The following is a description of a gene set: species: Homo sapiens Human Gene Set: HP_ABNORMAL_ANKLE_MORPHOLOGY Abnormal ankle morphology A structural anomaly of the ankle., and this is the list of marker genes: NSD1, COG8, FIG4, SLC4A10, ADSS1, ADAMTS15, COL25A1, EXT2, SVIL, ANGPT2, ATP5F1D, GABRG2, ERGIC1, ORAI1, FLNA, ITGA7, DPM1, CYP2R1, COL6A1, COL6A2, FGF13, MMP2, PNPT1, SCN1B, SYT2, COL6A3, EXT1, TNNT1, PIEZO1, NEB, SCN9A, SCN2A, UBA1, MAP3K20, MYL2, ACTA1, FKBP10, SELENON, IL2RA, HACD1, MAFB, IDH1, PTPN2, PSAT1, CHMP1A, SPG11, RYR1 (NCBI Gene Id 906), ANO5, ERLIN2, RAB3GAP2, ALAD, NFATC2, DYRK1A (dual specificity tyrosine phosphorylation regulated kinase 1A), SLC1A4, CD247, SCYL2, APC2, VARS1, PTPN22, VDR, NT5C2, COL10A1, LIFR, C18orf32, DAG1, SCN1A, KLHL9, HNRNPA2B1, MAN2B1, PRRT2 (proline rich transmembrane protein 2), C19orf12, DDR2, TPM3, ANKRD55, RTTN, SPTBN4 (NCBI Gene Id 80322), HNRNPH1 (heterogeneous nuclear ribonucleoprotein H1), STX1B, ESCO2, ADGRV1, IL2RB, GJC2, RPL10, SLC34A3 (NCBI Gene Id 142680), HCN1, CARS1, DNMT3A, GABRD, LGI4, PI4KA, CYP27B1, REEP1, TPM2, FLT4, COL12A1, STAT4, TOR1AIP1, CLCN5, CAPN3, NONO, SGCA